Given this list of marker genes Aif1, Mdk, Slit2, Coro1b, Gstp2, Nrp1, Lpar1, Gstp1, Pdgfd, here is a description of the gene set: studied in species Mus musculus Mouse Gene Set: GOBP_REGULATION_OF_SMOOTH_MUSCLE_CELL_CHEMOTAXIS Any process that modulates the frequency, rate, or extent of smooth muscle cell chemotaxis.